Given this list of marker genes PFKFB3, LONRF2, SGSH, PRKAA1, SPG11, MFSD8, NR3C1, GRP, C12orf57, ORMDL3, EXT1, MFSD2A, KCNQ3, IGLON5, GABRB3, B4GALNT1, DPP4, GMPPA, NAGLU, BORCS7, VPS13A, ELP6, VPS54, GRPR, ORMDL1, DCTN1, BCL7A, WDR47, SLC1A1, FMC1, GBA1, ATP1B2, ADARB1, TUBA1A, here is a description of the gene set: Human Gene Set: GOBP_MOTOR_BEHAVIOR The specific neuromuscular movement of a single organism in response to external or internal stimuli. species: Homo sapiens